The following is a description of a gene set: species: Homo sapiens Any process that modulates the frequency, rate or extent of regulatory non-coding RNA processing. Human Gene Set: GOBP_REGULATION_OF_REGULATORY_NCRNA_PROCESSING, and this is the list of marker genes: HOXB-AS3, BCDIN3D, PRKRA, LIN28B, TGFB1, TARBP2, LIN28A, BMP4, DGCR8, IL6, ZMPSTE24, TP53, STAT3, RIPK1, TRUB1, ZC3H10